Given this list of marker genes INPP5D, INPP5A, INPP5B, INPP5K, INPP5J, OCRL, here is a description of the gene set: Human Gene Set: GOMF_INOSITOL_1_3_4_5_TETRAKISPHOSPHATE_5_PHOSPHATASE_ACTIVITY studied in species Homo sapiens Catalysis of the reaction: 1D-myo-inositol 1,3,4,5-tetrakisphosphate + H2O = 1D-myo-inositol 1,3,4-trisphosphate + phosphate.